Given this list of marker genes Lrp1, Itgb1bp1, Dlc1, Apod, Coro1c, Acvrl1, Fam107a, Pten, Src, Rcc2 (regulator of chromosome condensation 2), Phldb2, Mmp14, Arhgap6, Dmtn, Dusp22, Clasp2, here is a description of the gene set: studied in species Mus musculus Mouse Gene Set: GOBP_NEGATIVE_REGULATION_OF_CELL_SUBSTRATE_JUNCTION_ORGANIZATION Any process that stops, prevents or reduces the frequency, rate or extent of cell-substrate junction organization.